Given this list of marker genes TAF1A, TBP, TAF1B, TAF1D, TAF1C, here is a description of the gene set: studied in species Homo sapiens A RNA polymerase I-specific transcription factor complex that contains the TATA-box-binding protein (TBP) and at least three TBP-associated factors including proteins known in mammals as TAFI110, TAFI63 and TAFI48. Human Gene Set: GOCC_RNA_POLYMERASE_TRANSCRIPTION_FACTOR_SL1_COMPLEX